Given this list of marker genes PML, PRKCG, MTNR1A, HUWE1, ADIPOQ, NR2F6, BMAL1, HNRNPU, TP53, NMU, ADRB1, GABRB3, IMPDH2, HEBP1, ATF4, PSPC1, GPR157, SCN11A, PROX1, CSF2, NOCT (NCBI Gene Id 25819), PASD1, BHLHE41, CAVIN3, RAI1, NDUFA9, OPN5, PTEN, ID1, PRKG1, GHRL, MYBBP1A, RORB, CHRNB2, PRKAA1, BTBD9, BTRC, OPN4, ADORA1, MAGED1, DRD4, GPR176, MTOR, RORA (NCBI Gene Id 6095), PHLPP1 (PH domain and leucine rich repeat protein phosphatase 1), SPSB4, NTRK3, NAMPT, DRD2, HNF4A, MTTP, JUND, PPARGC1A, PER2, ATF5, DDB1, SLC6A4, PIWIL2, KAT5, BHLHE40, SUV39H1, ZFHX3, BMAL2, ID3, METTL3, SREBF1, NPS, PPARG, PPP1CC, MTA1, AGRP, NAGLU, CIPC, ABCB1, EGR1, CCAR2, PTGDS, GSK3B, MAPK8 (NCBI Gene Id 5599), PARP1, USP2, KMT2A, NCOR1, THRAP3, RORC, ZPBP2, RELB, SCN9A, ADCY1, HNRNPD, TOP2A, NGF (nerve growth factor), CRY2, ANKFN1, PER1, ADORA2A, FBXW11, EZH2, USP7, ASS1, CDK1, MAGEL2, HCRTR2, NKX2-1, MYCBP2, BECN1, GNAQ, COL6A1, PPP1CA, PRMT5, TNFRSF11A, LEP, SOX14, NTRK2 (NCBI Gene Id 4915), ID2, MTNR1B, NR1D1, NOS2, NPAS2, GHRH (NCBI Gene Id 2691), HDAC3, KCNA2 (potassium voltage-gated channel subfamily A member 2), SUV39H2, MAPK9, PER3, NCOA2, NR1H3, SIAH2, NRIP1, KDM5A, MAPK10, FXR1, SIN3A, NTRK1, ROCK2, TARDBP, CLOCK, NFIL3, EGR3, RBM4B, AANAT, NUDT12, PRKAA2, FBXW7, CRTC1, FBXL3, SIX3, DRD3 (dopamine receptor D3), SETX (NCBI Gene Id 85506), ATG7, ID4, USP9X, ROGDI, GFPT1, C3orf70, NFILZ, HDAC2, PROKR1, BLOC1S6, CRY1, SRRD, SIK1, RPE65, DYRK1A, PRKDC, TIMELESS, AHR, RBM4, MC3R, PROKR2, PLN, FBXL21P (NCBI Gene Id 26223), KDM8, SIRT6, EP300 (NCBI Gene Id 2033), F7, GHRHR, PPP1CB, IGF1, UBE3A, KDM2A, CARTPT, PROK2, HDAC1, NLGN1, CSNK1E, CSNK1D, CLDN4, SIRT1, CREB1, PDE6B, TNF, CIART, SFPQ, KLF10, NR0B2, GNA11, HTR7, ATOH7, NR1D2, TOP1 (NCBI Gene Id 7150), OGT, NONO, OPN3, PPARA, NPY2R, KLF9 (NCBI Gene Id 687, KLF transcription factor 9), KCND2, NGFR, CRH, LGR4 (leucine rich repeat containing G protein-coupled receptor 4), here is a description of the gene set: studied in species Homo sapiens Any biological process in an organism that recurs with a regularity of approximately 24 hours. Human Gene Set: GOBP_CIRCADIAN_RHYTHM